The following is a description of a gene set: Human Gene Set: GNF2_RFC3 Neighborhood of RFC3 replication factor C (activator 1) 3, 38kDa in the GNF2 expression compendium studied in species Homo sapiens Neighborhood of RFC3, and this is the list of marker genes: RFC4, CCNA2, ASPM, SNRPD1, PAICS, MCM4 (minichromosome maintenance complex component 4), HMMR, FANCI, H2AZ1, BIRC5, TIMELESS, RANBP1, FOXM1, ADSL, SSRP1, TOP2A, SMC2, RAN, GINS2, PCLAF, UBE2C, NCAPD2, CKS2 (NCBI Gene Id 1164), CKS1B, MSH6, RRM1, MCM3, RAD51AP1, CTPS1, ITGB3BP, SUPT16H (NCBI Gene Id 6831), KIF11, NDC80, CENPE, PFAS, SMC4, MRPL35, CDK1, MCM6, RPA3, RFC3